Given this list of marker genes TUBAL3, TUBB1, TUBA3C, RAC1, DVL3, NUP160, FMNL3, TAOK1, CENPF, TUBA4A, CLASP2, NUDC, PFN1, ITGB1, CENPI, CDC42, TUBB4B, CENPL, SEC13 (NCBI Gene Id 6396), BUB3, CENPS, SPC25, SRC, NUF2, CLASP1, KIF2A, DAAM1, MAD2L1, TUBA8, TUBA4B, TUBA1B, DYNC1I1, NDE1, CENPK, SGO2, SRF, FMNL2, TUBB4A, MAPRE1, TUBA1C, ZWILCH, MIS12, PPP2CB, TUBB8, SKA1, KIF2C, RPS27, CENPP, CENPM, TUBA3E, ACTB, PPP2R1A, RCC2, CKAP5, PPP2CA, CDCA8, DYNLL1, PPP2R1B, BUB1, DSN1, NDC80, DYNC1LI2, TUBB3, NUP85 (nucleoporin 85), CENPN, BIRC5, RHOA, CENPU, PPP1CC, FMNL1, PMF1, NUP107, ZWINT, PAFAH1B1, KIF18A, NUP133, DYNC1LI1, RANBP2, EVL, PPP2R5A, DYNLL2, ACTG1, MAD1L1, TUBB2B, ERCC6L, DIAPH3, PFN2, RHOC, SPDL1, DVL2, CENPC, AHCTF1, SKA2, SEH1L, B9D2, DYNC1H1, PPP2R5E, PLK1, NUP43, NDEL1, CENPH, SCAI, TUBB8B, SPC24, DIAPH1, DVL1, CENPE, CENPQ, PPP2R5C, KNL1, SRGAP2, KIF2B, TUBB6, XPO1, DYNC1I2, CENPT, NUP98, SGO1, CENPA, RHOD, NUP37, ZW10, RANGAP1, TUBB2A, MRTFA, TUBA3D, CENPO, CLIP1, DIAPH2 (diaphanous related formin 2), RHOB (NCBI Gene Id 388), INCENP, ITGB3BP, PPP2R5B, PPP2R5D, AURKB, NSL1 (NSL1 component of MIS12 kinetochore complex), BUB1B, TUBA1A, CDC20, KNTC1, here is a description of the gene set: RHO GTPases Activate Formins studied in species Homo sapiens Human Gene Set: REACTOME_RHO_GTPASES_ACTIVATE_FORMINS